Given this list of marker genes MTF2, SLC16A3, CENPE, PCLAF, DEPDC1, PRR7, TOP2A, PSMA5, RPP25, CDC25C, ARFGEF2, MAPKAPK5, CMAS, SAP30, PAWR, SLC38A1, NBN, H2AX, CBX5, WARS1, F12, LRIF1, CDKN2A, CCNE2 (cyclin E2), GLMN, FBXO5, UBA6, PPFIA1, LRPPRC, SEC23A, FUT9, SS18, ARPP19, CSE1L, BPNT2, POLR3G, KIF4A, CDK5R1, KPNA2, RAN, HDGFL3, MRPL12, HK2, ADM, ANGPT2, CDC7, ACTR3, AP2B1, RFC4, BUB1B, ACP1, WDR43, YKT6, PHF10, SRD5A1, MRPL42, SMG1P5, NEK2, DR1, EIF3JP1, KCTD5, HEXIM1, THOP1, CENPA, CDC27, DDA1, DSN1 (NCBI Gene Id 79980), TUBA4B, TACC3, PPP2R3C, NCAPH, ESM1, CCDC59, STC1, GSS, ATAD2, PTTG3P, GINS2, DNAJA1, PSMD12, VRK2, NCBP1, TUBA4A (NCBI Gene Id 93373), YME1L1, ERCC6L, RAB22A, GPSM2, MRPL13, RGS20, STC2, PPM1G, PTBP3 (NCBI Gene Id 9991), NETO2, SLC9A2 (solute carrier family 9 member A2), NUP210, SLC2A1, TPRKB, E2F8, RAD54L, ELOVL6, RALA, UBE2V1, MEMO1, EZH2, NSD2, PLK4, FBXO11, GNAS, DNM1L, SLC16A1, WDHD1, VEGFA, UBE2N, RUVBL2, MRPL19, RACGAP1, KNTC1, TBC1D31, MYO7A, GPR19, NTAQ1, TUBA3C, STEAP1B, CDC25A, TIMM8A, KRT8P17, CENPI, RTCA, DGUOK, CEP43, CDC45, UBAC1, TFDP1, YEATS2, TTF2, BRCA2, PLOD2, RAD51AP1, RFC3, CKS2, IL2RA, CDCA3, NUP37, LMNB1, SFXN1, NRAS, SMNDC1, GPR37 (NCBI Gene Id 2861), UBE2V2 (NCBI Gene Id 7336), MAP6D1, DSP, KLC1, EIF4A3 (NCBI Gene Id 9775), NME1, CARHSP1, UBE2C, NCAPD3, DUSP9, ANKLE2, ACOT7, CD70, TAF7L, STMN1, PPIAP21 (peptidylprolyl isomerase A pseudogene 21), PRIM2, HDAC2, NAB1 (NGFI-A binding protein 1), KLRC1, MFSD12, CMC2, MCM5, CCDC93, KIF2C, FOXM1, EGLN3, CDT1, CCNB1, RECQL, CDK1, CKAP2, COMMD8, H2AC11, NUP62, KIF23, INTS13, PVR, RECQL4, PARPBP, MCM4, XPNPEP1, CIAO1, NCAPD2, CENPN, HMMR, WASF1, TOMM40, PGK1, HELLS, BUB1, MAD2L1, RIF1, TBRG4, ELOVL4, PBK, KIF18B, HBS1L, FIP1L1, CCNA2, KIF15, CENPM (centromere protein M), SSX2IP, CDCA8, NOLC1, SEMA3A, NDUFA9, NEIL3, YEATS4 (YEATS domain containing 4), GINS4 (GINS complex subunit 4), KAZALD1, MTCH2, MTPAP, PYGL, PRMT1, SHCBP1, KRT8P11, CDYL, PHTF2, CENPF, QSER1, TRMU, XRCC3, TUBA3E, HJURP, MELK, PSMB2, HAT1, POLE2, MYBL1, TSR1, CEP55, GGH, IGF2BP3, GCH1, NCAPG2, LRFN4, PAX8, IL1RAP, MTHFD2, SLC7A5 (solute carrier family 7 member 5), EXO1, TMEFF1, NABP2, PTTG1, EIF4E2, CSNK1D, TFPT, STRN4 (NCBI Gene Id 29888), RASAL2, TRIP13, WDR62, MAGEA3, EIF5B, DBF4, ERO1A, MAGOHB, CBS (NCBI Gene Id 875), CDKN3, PA2G4 (proliferation-associated 2G4), ASPM, CDKN2C, CHRNA5, ARL4D, NAA50, ZNF248, KMT5AP1, AP2S1, SAR1A, ATG5, TMEM38B, GINS3, MRGBP, VANGL1, DLGAP5, CDC20 (cell division cycle 20), TYMS, HMGA1, PNP, POMT2, BUB3, MOB1A, PSRC1, MED8, OR7E12P, SKA1, PRKAA2, KRR1, NCAPG, SNX7, IPO5, OIP5, ERN1, GABPB1, SRM, PKP2, UBE2K, MSH6, SPC25, EIPR1, GINS1 (GINS complex subunit 1), MTIF2, CNOT9, KIF18A, ORC1, CDC6, HAUS3, NEMP1, HMGB2, PTTG2, GPD2, PNKP, NUSAP1, TWSG1, BIRC5, TNNT1, COL2A1, HCCS, PDCD2, JPT1, EIF4EBP1, MIF, MPHOSPH9, LSM4, KIF20A, TUBG1, ZWINT, KIF2A (NCBI Gene Id 3796), SCD, TTK, H2AZ1, ARTN, MCM6, ENPP1, KIF14, UBE2D1, SYNCRIP, AURKB (NCBI Gene Id 9212), DNAJC9 (DnaJ heat shock protein family (Hsp40) member C9), DARS1, SLBP, MCM10, MYBL2, LDHC, MMP12, CCNE1, PPIF, NUDT3, RRM2, SNX6, TEX30, TROAP, TFG, ACD, AGMAT, PPID, MKI67, PSMA7, SLC25A10, RFC2, TCP1, GAPDH, PRC1, H2BC9, DTL, CORT (cortistatin), UGT8, RBL1, TWF1, UBE2S, PFKP, PRKDC, C6orf120, RNMT, ITCH (NCBI Gene Id 83737), FANCI, DNA2, DENND1A, AURKA (NCBI Gene Id 8465), PPARD, SEPHS1, GMFB, SNRPB, DCK, ZSCAN5A, PRIM1, FANCA, EXOSC2, PGM3, ADRM1, PMAIP1, CHEK1, WDR76, IL18RAP (interleukin 18 receptor accessory protein), PITX1, GOLT1B, TEAD4, FKBP4, DTYMK, PRPS1, APOBEC3B, AGPAT5, RC3H2, NDC80, CCT5, PAICS, PKM, SNRPA1, SMC2, PPAT, AK4, CCL7, PSAT1, PCNA, TK1, FCHO1, PLIN2 (perilipin 2), R3HDM1, PSME3, SZRD1, PCMT1, WAPL, ZWILCH, GTSE1, CALM3, GNAI3, SOD2, SPAG5, MUC16, RIPK2, NMU, SNCG, LDHB, CENPU, KIF11, PIMREG, TPX2, GCFC2, CENPQ, CTSV (cathepsin V), CDKN2D, CCNB2, CPT1A, CLPB (ClpB family mitochondrial disaggregase), PFN2, ATP2B1, FOXG1, AFP, CAD, BRIP1, SMC6, FAM216A, here is a description of the gene set: from publication Director's Challenge Consortium for the Molecular Classification of Lung Adenocarcinoma, Shedden K, Taylor JM, Enkemann SA, Tsao MS, Yeatman TJ, Gerald WL, Eschrich S, Jurisica I, Giordano TJ, Misek DE, Chang AC, Zhu CQ, Strumpf D, Hanash S, Shepherd FA, Ding K, Seymour L, Naoki K, Pennell N, Weir B, Verhaak R, Ladd-Acosta C, Golub T, Gruidl M, Sharma A, Szoke J, Zakowski M, Rusch V, Kris M, Viale A, Motoi N, Travis W, Conley B, Seshan VE, Meyerson M, Kuick R, Dobbin KK, Lively T, Jacobson JW, Beer DG (PMID 18641660) Cluster 6 of method A: up-regulation of these genes in patients with non-small cell lung cancer (NSCLC) predicts poor survival outcome. species: Homo sapiens Although prognostic gene expression signatures for survival in early-stage lung cancer have been proposed, for clinical application, it is critical to establish their performance across different subject populations and in different laboratories. Here we report a large, training-testing, multi-site, blinded validation study to characterize the performance of several prognostic models based on gene expression for 442 lung adenocarcinomas. The hypotheses proposed examined whether microarray measurements of gene expression either alone or combined with basic clinical covariates (stage, age, sex) could be used to predict overall survival in lung cancer subjects. Several models examined produced risk scores that substantially correlated with actual subject outcome. Most methods performed better with clinical data, supporting the combined use of clinical and molecular information when building prognostic models for early-stage lung cancer. This study also provides the largest available set of microarray data with extensive pathological and clinical annotation for lung adenocarcinomas. Human Gene Set: SHEDDEN_LUNG_CANCER_POOR_SURVIVAL_A6